The following is a description of a gene set: from publication Cui A, Huang T, Li S, Ma A, Pérez JL, Sander C, Keskin DB, Wu CJ, Fraenkel E, Hacohen N (PMID 38057668) Cytokines mediate cell-cell communication in the immune system and represent important therapeutic targets. A myriad of studies have highlighted their central role in immune function, yet we lack a global view of the cellular responses of each immune cell type to each cytokine. To address this gap, the authors created the Immune Dictionary, a compendium of single-cell transcriptomic profiles of more than 17 immune cell types in response to each of 86 cytokines (>1,400 cytokine-cell type combinations) in mouse lymph nodes in vivo. A cytokine-centric view of the dictionary revealed that most cytokines induce highly cell-type-specific responses. For example, the inflammatory cytokine interleukin-1β induces distinct gene programmes in almost every cell type. A cell-type-centric view of the dictionary identified more than 66 cytokine-driven cellular polarization states across immune cell types, including previously uncharacterized states such as an interleukin-18-induced polyfunctional natural killer cell state. Genes negatively differentially expressed in cell type: cDC2 (conventional dendritic cell type 2) upon treatment with cytokine: M-CSF in mouse lymph nodes in vivo. Mouse Gene Set: CUI_CDC2_M_CSF_RESPONSE_DN studied in species Mus musculus, and this is the list of marker genes: Ddx5, Atf3, Hspa1a, Slamf7, Cox7a2l, Mycbp2, Pmaip1, Neat1, Btg2, Eif3f, Fos